The following is a description of a gene set: studied in species Mus musculus Mouse Gene Set: REACTOME_INITIATION_OF_NUCLEAR_ENVELOPE_NE_REFORMATION Initiation of Nuclear Envelope (NE) Reformation, and this is the list of marker genes: Ccnb1, Lmna, Ankle2, Rbm39, Cdk1, Banf1, Lbr, Lmnb1, Ppp2r2a, Ccnb2, Sirt2, Ppp2r1a, Kpnb1, Ppp2ca, Vrk1, Emd, Vrk2